The following is a description of a gene set: species: Homo sapiens Human Gene Set: REACTOME_PRC2_METHYLATES_HISTONES_AND_DNA PRC2 methylates histones and DNA, and this is the list of marker genes: H3C13, H3C11 (NCBI Gene Id 8354), H2BC14, H4C12, H3C2, H4C3, H2BC3, H3C1, H2BC7, H2AZ2, H4C11, H2BC15, H2AC20, H2BC13, PHF19, H4C16, H2BC1, H3C7, H4C13, H2BC10, H4C6, H2BC12, H2AC6, H3C10, H3C14, DNMT3B, RBBP7, RBBP4, H2AC8, H3C12, H2BC8, H4C2, H4C9, H3-3B, H2BC26, DNMT1, AEBP2, DNMT3A, H4C1, H2BC21, SUZ12, H3-3A, MTF2, H3C8, PHF1, H2BC5, EZH2, H4C15, H2BC9, H3C15, H2BC6, H4C8 (H4 clustered histone 8), H2BC4, H2AJ, EED, H2BC17, JARID2, H2AC18, H3C4, H2AC4, H4C14, H2AC7, H3C6, H2AX, H3C3, H2BC12L, H2BC11, H4C5, H2AC19, H2AC14, H2AB1, H4C4